The following is a description of a gene set: from publication He P, Lim K, Sun D, Pett JP, Jeng Q, Polanski K, Dong Z, Bolt L, Richardson L, Mamanova L, Dabrowska M, Wilbrey-Clark A, Madissoon E, Tuong ZK, Dann E, Suo C, Goh I, Yoshida M, Nikolić MZ, Janes SM, He X, Barker RA, Teichmann SA, Marioni JC, Meyer KB, Rawlins EL (PMID 36493756) species: Homo sapiens Human Gene Set: HE_LIM_SUN_FETAL_LUNG_C3_INTERMEDIATE_LYMPHATIC_ENDO_CELL Intermediate lymphatic endo, and this is the list of marker genes: CXCL2, RARRES2, DOC2B, ATP9A (NCBI Gene Id 654090), IGFBP5, GLT8D2 (glycosyltransferase 8 domain containing 2), FAM110B, TLR4, PLD1, THEMIS2, SGK3, RAB11FIP5, TGFA, SLPI, STON2, DOCK8, OXCT1, PCLO, CXADR, ABO, NFIA-AS2, TPBG, LRCH2, LINC00636, SULF2, GPR182, VSTM4, LRRN4CL, RAB11FIP1, CHRDL1, CRNDE, GUCY1A1 (guanylate cyclase 1 soluble subunit alpha 1), ADAM22, HSPA2, CD38, PDE2A, ZSCAN16, MFAP4, KCNN3, C17orf58, PDE1A, TLE1, DAPK1, PGM5, EDNRB, STOX2 (storkhead box 2), TTN, A4GALT, CRTAC1, LY96, BCL2L11, SYNE1, LGALS3 (NCBI Gene Id 81625), CALHM2, PGM1, MGST1, NICOL1, BHMT2, AK4, C20orf204, SDC3, ZDHHC14, MFSD4A, PKHD1L1, EPHB1, SEMA3D, FMOD, PTX3, ALDH3A2, MITF, TMTC1 (transmembrane O-mannosyltransferase targeting cadherins 1), PDLIM4, APOE, CALHM6, RAB29, KHDRBS3, MATN2, NBL1, HAPLN3, SGCD (sarcoglycan delta), RADIL, SNX10, MAP3K1, IFT57, GAS7 (NCBI Gene Id 8522), NMNAT2, ACKR2, CTBS, SLC26A4, NTN1, PTPRE, ANKRD6, DDX10, TFF3, ARRDC4, SCRN1, ADIRF, FBN1 (fibrillin 1), C1QTNF4, UNC5B, SRGAP3, PDGFA, SFXN3, WASF3, GCNT2, DNASE2, PLEKHA4, RHOD, CYB561A3, THBS1, OAS1, GNG12, OLFML1, FILIP1, EEIG1, ALDH1A1, AGAP1, FHL2, LYPD6, NAAA, BHMT, STAB2, RCAN1, AHNAK2, IGF1, ARID5B, RHOU, SMAD9, ASGR1, GPM6A (NCBI Gene Id 2823), SPR, FAM171B, OSBPL1A, CCDC122, NLGN4X, PLAC9, LTBP4, ELK4, SCN3B, FCGR2A, GNB5, AHI1, FZD10, NR2F2-AS1, FOXC2, IER3, ACSL5, PRKAA2, DTX1, SLC5A3, LYRM1, C6orf141, ITGAV, PLPP1, PTGR3, TSPYL2, NR1H3, RASSF10, F8, PTGS1, RPP25, TRIM47, TANC2, KBTBD11, PDPN, LETR1, TMOD2, KLF12, LRP11, BMX, TFEB, CLIP3, ITPK1, NNMT, ABI3BP, LINC01116, ADAMTS9 (NCBI Gene Id 56999), COQ8A, THBS3 (thrombospondin 3), TRIP6, HOXD3, TM7SF2, APOLD1 (apolipoprotein L domain containing 1), HOXD9, ITGB8, PGM5-AS1, FHIT, PELI2, DBNDD1, TNFAIP8L3, SSH1, OMG, HOXD8, TTC8, EPS8L1, HYAL3, SLC7A1, SLC25A23, MYO5C, SLC35F6, GLRB, CMKLR2, SYNPO, ZNF385A, NUPR1, AKR1C2 (NCBI Gene Id 6994), ASPH, PLEKHO2, CYP4X1, EFEMP1, SCG3, PLIN5, APBA2, SFT2D2, EPB41L1, HS3ST1, AKR1C3, GALNT2, TMEM120A, MAN1C1, MPP7, PLA2G4C, EBF1, MVP, ZDHHC17, CCDC102B, GLRX, TMEM38B, ECHDC2, DCHS2, CNST, BCR, SLC30A3, STIM1, NIPAL2, ST6GALNAC3, MAGED4B, RAB6B, ANG, SIRPA, AKR1C1, PTPN3, SLC41A1, RASSF9, OSBP, DKK3, ARL15, NR2F1-AS1, CEP85L, FAM174B, PARD6G (par-6 family cell polarity regulator gamma), TMT1A, CYP27A1, ABCA3, TAC3, MOB3B, PDGFC, SBSPON, OAF, CABLES1, PROX1, PPP1R9A, MEST, ARK2C, MRC1, COL4A5, CEACAM1, HSD3B7, COLEC12, HOXB4 (NCBI Gene Id 3214), S100P, ZNF490, CTDSPL, EFNA5, REEP1, PTPRS, PRKCZ, CFI, PPARG, LRRC70 (NCBI Gene Id 353281), RNASE4, PDLIM3 (NCBI Gene Id 27295), DSEL, MAN1A1, SCN3A, CYP1B1 (NCBI Gene Id 1545), SLC43A3, TSHZ2 (NCBI Gene Id 7765), KLHL3, LRIG3, GIMAP5, PAIP2B, LGALS7, EPHB2, FOXP2, DPP4, SGCE, TCTN3, SLC45A3, FZD6, NEXN, CCNJ, LAMB1, TSHZ1, MAGED4, DTX4, KLHL4, TNFRSF11A, SNCG, UBAP1L, PDIA5, FLRT2, SEMA3A, PLAAT4, TBX1, SEMA4D, PDLIM1, TRADD, PDGFD, HES4, FLNC, FBXO44, TRMT9B, GDF10, SLC38A1, CAMK2D, IGSF3, CELSR1, MXRA8, DNAAF4, SLC24A1, SCARA3, CCN1, NR2F1, PRKAG2, TPD52, GSTM3, ITGA9 (integrin subunit alpha 9), LAPTM4B (lysosomal protein transmembrane 4 beta), CTTNBP2, PEG10, BCHE, NEO1, CASK, SMYD2, GLIS3, MEDAG, CCDC141, SHC2 (NCBI Gene Id 400665), PMP22, RELN, CCL21, MET, COL9A3, PRKAG2-AS1, NFATC1, SYNM, PSEN2, PGAP4, B3GNT7, DOCK5, CCDC80, HCLS1, GLS, SCNN1B, UNC93B1, DNPH1, CAMK1, NTS, ADAMTS12, PDE7B, ENTREP1, C1orf198, CYP39A1, SLC38A4, HOXA7, SLC22A23, CEP19, PTPN14, MID1, ULK2, NINL, IL7, FILIP1L, NFATC2, CDC42EP5, ITGB4, FOXP4, MYEF2, FBLN2, IRF8, ABCA4, LINC01117, PHLDB3, RAB3IL1, MCUB (mitochondrial calcium uniporter dominant negative subunit beta), SETD9, GALNT1 (polypeptide N-acetylgalactosaminyltransferase 1), ROBO3, DLGAP1-AS1, SMOC1, CPXM2